The following is a description of a gene set: Abnormal change in sexual drive An abnormal change in libido (sexual desire), typically accompanied by an altered frequency of sexual activity compared to from a person's previous norm. species: Homo sapiens Human Gene Set: HP_ABNORMAL_CHANGE_IN_SEXUAL_DRIVE, and this is the list of marker genes: TRANK1 (NCBI Gene Id 9881), ATP7B, TDO2, GRN, PTRHD1